Given this list of marker genes PRKCSH, TGIF1, NHERF4, CNTFR, TNNC1, SEC16B, MTMR4, NYAP1, WNT3, PTMS, PEX16, LEAP2, MAP3K11, RAB15, PSME3IP1, UNC5B, CRYBG2, JMJD1C, DRD3, CRABP2, PEPD, F10, BAALC, ZBTB40, SMG5, TCF12, ZSWIM8, CPLX2, SHF, TRIM47, GLUD1, FUT8, HTN1, ARCN1, ASB7, ODAD3, PRDM16, GOLGA4, PDE8A, ARFGEF2, PHF21B, IGF1R, SREBF2, SOS1, VWCE, KLF3-AS1, MANEA, NR2C1, TP53BP1, IFFO1, MREG, SNAI1, SELENOM, GTF2I, ACTB, CDK16, HNRNPAB, ADGRL2, DNAJC22, CALM3, PPARA, CCDC106, COL8A1, PRKACA, ATAT1, MIR22HG, PRG4, ADGRA2, CNOT1, NRAP, FXYD1, WRAP53, DUSP3, SCNM1, MRPS28, PLLP, GBF1, ZSWIM3, PRKAG1, SPRY4 (sprouty RTK signaling antagonist 4), SLC26A6, NR2F1, BCL11A, FAM170A, ETV6, SERPINC1, INHBC, MAP1B, MOV10, SLC22A11, RARB, NEK6, XPR1, TSPAN13, MPRIP, SELENOP, UBE2K, SRSF6, ST18, PRODH2, PIK3R3, PRRX2, HOXA9, HSD17B8, NOVA1, PIPOX, ESRRA, TPGS2 (tubulin polyglutamylase complex subunit 2), COL15A1, ESRP2, PROX1, FBLN1, CA12, GCC2, HDGF, ACSL5, CBLN4, PALS1, HIKESHI, REEP4, RSPRY1, LGALS4, EVX1 (even-skipped homeobox 1), CUTA, PPP1R14D, NAGS, RPRD1B, ZBTB45, INVS, LRRC19, PPARGC1A, DOCK11, MISP, CDK5R1, ERBB2, TOMM70, EFEMP1, INSR, HNF1B, AP1B1, DIS3L, TAOK3 (TAO kinase 3), RAPGEFL1, HR, PCBP4, MLEC, LHX1, SLC39A5, USH1C, PAK4, GATA4, RBMS1, SELENOI, KCNE5, AKT2, PRR14 (proline rich 14), CCDC71, TMEM79, RCN2, TEX2, UQCR10, MYRF, GLTP, BAZ2A, HOXA10, PAX7, LRRTM3, CLCNKA, PNPLA2, HEPH, POLD4, PICALM, EBF2, RHOB, LMO3, CELF3, NXPH4, GMPPB, CCNJL, DQX1, CYP1A1, KLF3, MSI1, AKAP11, DCTN2, NR2F6, HOXD3, ASXL1, GBE1, GALNT2, ADAMTS19, AGPAT1, CRY2, TRAF4, DAB2IP, ASAH2, RTP3, CLRN3, SLC39A4, IYD, KCNK10, TBC1D13, GGN, LAMP2, LINC01101, ACOT8, DNAJA2, NR2F2, CLUH, TP53, LRP1, TTI1, SRSF4, LINS1, POU5F1, RBP2 (retinol binding protein 2), SLC25A47, HNF1A, NLRP6, CREBRF, CHMP4B, RBKS, AP5B1, ATP1B4, PRKCD (protein kinase C delta), EIF4G1, BCL2L14, PON1, NRXN1, RNF5, SYT6, OTC, ILRUN, MYH10, KYNU, WDR81, RTN4, C1orf210, AGPS, FEZF2, TLE1, SERTAD4, ZBTB18, ACOT7, NRG2, LYSMD1, HIRA, MARK2, UBE2R2, PDZK1, NR4A1, EHD1, MRPL40, OBSCN, TLK2, RAB5C, ZIC4, here is a description of the gene set: studied in species Homo sapiens Human Gene Set: HNF4_01_B Genes having at least one occurrence of the motif NRGGNCAAAGGTCAN in the regions spanning 4 kb centered on their transcription starting sites. This matches the HNF4A transcription factor binding site V$HNF4_01_B (v7.4 TRANSFAC).